The following is a description of a gene set: species: Homo sapiens Genes down-regulated in comparison of CD4 CD8 thymocytes versus T cells from cord blood. Human Gene Set: GSE1460_DP_VS_CD4_THYMOCYTE_DN from publication Lee MS, Hanspers K, Barker CS, Korn AP, McCune JM (PMID 15210650) Subpopulations of human fetal thymocyte and circulating naïve T cells were obtained through FACS sorting, including CD3-CD4+CD8- intrathymic T progenitor cells (ITTP), CD3intCD4+CD8+ \double positive\ thymocytes (DP), CD3highCD4+CD8- \single positive\ thymocytes (SP4), CD3+CD4+CD8-CD45RA+CD62L+ naive T cells from cord blood (CB4+), and CD3+CD4+CD8-CD45RA+CD62L+ naive T cells from adult blood (AB4+)., and this is the list of marker genes: CXCL12, GDF5, IL2RB, GALNT10, PBOV1, ACVR1B, TUBA4A, EHD1, CDO1, DDX60 (DExD/H-box helicase 60), NDRG2, GNA14, SP140L (NCBI Gene Id 93349), ARRB1, KRTAP4-7, IFI44, DENND2D, ARL6IP5, KIF5A, SIK1, ZNF516, IL6ST, MICAL2, PAM, FCGR2B (NCBI Gene Id 2213), BCL2A1, ICOS, FUCA1, HLA-B (NCBI Gene Id 730410), ITM2A, GRB10 (NCBI Gene Id 9769), ZNF365, SCN5A, BMP2K, FCGBP, TTC4, UBE2D2, PDGFA, BMP6, SPTBN1, ABCA8, CAMSAP2, PDE4B, SFXN3, PLOD1, RSAD2, FPR1, APP, SLFN12, SGPL1, HOXD1, THEMIS2 (NCBI Gene Id 9473), PLEKHA1, SP110, CHST15, S1PR1, SMAD7, SH3YL1, KCNJ8, TMEM204, ARHGAP45, RAB29, SLC16A5, IQSEC1, CYTIP (NCBI Gene Id 9595), HEY1, PIK3CD, ROBO1, NME3, RAB8B, TNFRSF25, EPAS1 (endothelial PAS domain protein 1), SP100, RASGRP2, COTL1, SP140, LAP3, ZNF512B, HCP5, NNMT, RIOX2, PCYOX1, VCL, DIAPH1, KLF10, CTSB, ABR, MS4A12, PDE4D, TPM4, SMAD3, PDIA5, EEIG1, CYTH4, SCN3A, RPS23, VTCN1, SELL, EPHB1, INPP1, CCR7, BTN3A1, B3GNTL1, ULK2, IL4R, SPON1, ST6GAL1, HGSNAT, JUND, MAN1C1, CD44, KLF2, STC1, CPQ, ZNF16, BMX, CTRB2, ERMP1, GPR65, STK10, WDR1, PPFIBP2, EVL, ADARB1, HLA-C, RNF39, TRAF3, PIK3IP1, ASAH1, EMP3, CTSL, PDIA4, ZNF140, ACP5, TMSB10, RPL12, SIRT6, OAS2, LRRN3, ZFP69B, SCARB2, PRKCA, LINC00623, CD55, IFI44L, CASP1, CLCA4, KDSR, NR4A3, RGS1, CPA3, LY86, EDNRA (NCBI Gene Id 1909), ZFP36L1, TPT1, ABLIM1, ADIPOQ, NHLH2, LPIN2, SLCO1A2, SRPRB, B4GALT4, STAT1, APCS, HLA-E (NCBI Gene Id 3133), RPGRIP1, CD53, RPL4, SLC7A7, CBLB, GVINP1, NLRP1, IL16, TBC1D4, GNG7, ASAP3, MLLT3, LY9, ACTN1, RPL3, GPR171, GALNT11, NPM1, GBP2, SCML1, RNF2, CRYBG1, TNFSF10, CCND2, SOX9, ART3, PLAC8, CYP3A4, EXD2, DCLRE1A, AHR, ZNF276, STK17A, KRT9, ELK3